Given this list of marker genes VANGL1, CDKN1B, DIS3L2, SLC2A10, CFI, COMT, MLXIPL, CLCN2, CTNNB1, SCNN1B, LYZ, MDH2, STAT2, HSD11B2, WNK1, INVS, IFT74, CLIP2, FCGR3B, SMARCAL1, MFAP5, KIAA0319L, MYCN, DHCR7, RNU7-1, IDS, PDE11A, MTRR (NCBI Gene Id 4552), PRKAR1A, HLA-B, TNFSF4, TMEM237, TGFB2, BSND, ALG9, NOTCH3, H4C3, DST, BBS2, SMAD4, COL4A3, P2RY11, C3, BBS9, MT-TF, ASL, WT1, GATA5, IDUA, CFAP418, IFNG, EXOSC2, SEC61A1, NPHP3, STAT1, TGFBR2, SCN2B, SPP1, NF1, XYLT1, RREB1, GPR101, FMO3, ADRA2A, ATRX, CEP19, TLR7, CORIN, ACVRL1, CR2, CDKN2B, DNAJB11, HCRT, ARHGAP31, TMEM70, LIPE, TNFAIP3, HMBS, CTSH, CFHR1, MT-TW, KIF1B, FGA, ANGPTL6, C4A, APOA1, CIDEC, BRAF, ABCG8, CDH23, STAT4, PDE3A (phosphodiesterase 3A), TTC8, COQ7, BICC1, PPARG, MEN1, IFT27, LRP6, HPSE2, KLHL3, IQCB1, PRKACA, ETS1, HLA-DPA1, EIF4H, MKKS, RET, SDHD, SLC7A7, CYP17A1, NOTCH1, TP53, BBS10, MMP2, CCR6, ARL6, CTLA4, BBS1, TNFRSF11A, MYLK, PDCD1, FLT1, AIP, TNIP1, MMP14, JMJD1C, SCAPER, NR3C2, CYP11B1, PXK, TREX1, CEP164, MUC1, ARMC5, BANF1, KCNJ10, CEP290, ECE1, DNMT3A, FKBP6, GEMIN4, UFD1, DZIP1L, HACE1, NOTCH2, NSMCE2, HIRA, NPHP4, MLX, SDHB, MT-TV, MT-CO1, SLC25A11, BBS12, SCLT1, CLDN16, MBTPS2, CELA2A, TSC2, DCDC2, DEPDC5, MAT2A, FBN1, GUCY1A1, ACBD6, FUZ, ZFX, HLA-DRB1, SDHC, TRIM32, ACTN4, HTRA1, ABCB6, MED12, EDA, ENG, PAX2, CACNA1D, ADAMTSL4, CLCNKA, BANK1, NEK8, POU3F4, MT-TQ, LZTFL1, NR3C1, MEF2A, ERCC4, WDR19, LMNA, PCSK9 (proprotein convertase subtilisin/kexin type 9), STX1A, REST, MT-CO3, LRIG2, CFB, TGFBR3, TRIM28, MT-ND6, MT-CO2, FIG4, ERCC8, SDHAF2, POR, SCNN1G, HNRNPK, THBD (NCBI Gene Id 7056), SDCCAG8, BUD23, HEY2, WDPCP, SLC37A4, TMEM67, THSD4, OSGEP, IRF5, GTF2I (general transcription factor IIi), IFT140, WRN, TGFBR1, KDM1A (lysine demethylase 1A), GTF2IRD2, TRIP13, MYH11, IL12B, SLC35A2, LOX, ELP1, COL3A1, ELN, HGD, TMEM270, C4B, THSD1, PRNP, CD46, LMX1B, PLAAT3, CAV1, CBS, MOG (NCBI Gene Id 4340), CDKN1A, SH2B3, ITGAM, MTFMT, FN1, BBIP1, ZMPSTE24, G6PC1 (glucose-6-phosphatase catalytic subunit 1), ALG5, CPOX, BLK, EPAS1, MECP2, PPOX, SCNN1A, IL10, COL4A5, MAFB, EXT2, LARS2, CDKN2A (NCBI Gene Id 1029), GCH1, ERCC6, VAC14, ZNF365, STOX1, PLIN1, SUGCT, CLCNKB, BAZ1B, CFHR3, DNAJC30, IFT172, JAK2, ENPP1, CCN2, MGP, MT-TL1, EPOR, PHOX2B, BRCA2, SMAD3, GANAB, MT-TK, LDLR, GP1BB, BSCL2 (BSCL2 lipid droplet biogenesis associated, seipin), SEC24C, PKD1, HLA-DQB1, METTL27, ARVCF, CFH, NDUFAF6, FOXE3, ITGA8, CC2D2A, APOB, MT-ND5, FH, ACAT1, ALX4, SMAD6, LIMK1, ACP5 (NCBI Gene Id 54), FGFR2, MT-ND1 (mitochondrially encoded NADH:ubiquinone oxidoreductase core subunit 1), POU6F2, SLC30A9, ZNRF3, NFIX, TMEM127, GNAS, IFIH1, TRPC6, PHF21A, CACNA1H, BMPR2, XPNPEP3, H19, TBL2 (transducin beta like 2), SMAD2, EDA2R, NOD2, UBE2L3, TBX1, DLST, APRT, LBX1, WDR35, MYMX, PKD2, LIN28B, ADA2, BBS7 (Bardet-Biedl syndrome 7), VHL, FMR1, PBX1, SDHA, EGFR, NCF1, PKHD1, ABCG5, DYRK1B, PRKG1, MT-TS2, JAZF1, IRAK1, LRPPRC, NKX2-5, TRAF3IP1 (TRAF3 interacting protein 1), DEF6, ALMS1, XYLT2, TSC1, ABCC6, INF2, BBS5, MT-TC, BNC2, MKS1, PRTN3, USP48, MAX (NCBI Gene Id 4149), USP8 (ubiquitin specific peptidase 8), SERPINA6, IGHG1, LDLRAP1, KCTD1, PIGA, KRT18, NOS3, SPRY2, ABCB4, BRCC3, CCND1, VPS37D, DNASE1, WNK4, LMO1, HR, FCGR2B, PAM16, GPC3, LEMD3, CDKN2C, NR4A2, TERT, GBA1, MC4R, PTPN22, NPHP1, CYP11B2, ACTA2, YY1AP1, CEP83, HMOX1, HBB, MT-CYB, CUL3, OFD1, TGFB3, COL4A4, ALK, RNU4ATAC, KCNJ5, GLA, CD2AP, CYP21A2, CCDC28B, HLA-DPB1, GTF2IRD1, MDM2 (NCBI Gene Id 84825), BBS4, IMPDH2, UMOD, LAMB2, MYMK, RFC2, TNFRSF11B, here is a description of the gene set: studied in species Homo sapiens Human Gene Set: HP_HYPERTENSION Hypertension The presence of chronic increased pressure in the systemic arterial system.